The following is a description of a gene set: studied in species Mus musculus Mouse Gene Set: GOBP_NEGATIVE_REGULATION_OF_CHROMATIN_BINDING Any process that stops or reduces the frequency, rate or extent of chromatin binding. Chromatin binding is the selective interaction with chromatin, the network of fibers of DNA, protein, and sometimes RNA, that make up the chromosomes of the eukaryotic nucleus during interphase., and this is the list of marker genes: Btaf1, Myod1, Senp2, Ppp3ca, Fbh1, Tdg, Nfatc4, Mepce, Wapl, Larp7